Given this list of marker genes Apom, Apoc3, Apoe, Trem2, Apoa2, Apoc2l, Gpld1, Apoc2, Scarb1 (NCBI Gene Id 52288), Lipg, Ldlr, here is a description of the gene set: Mouse Gene Set: GOBP_HIGH_DENSITY_LIPOPROTEIN_PARTICLE_CLEARANCE The process in which a high-density lipoprotein particle is removed from the blood via receptor-mediated endocytosis and its constituent parts degraded. studied in species Mus musculus